Given this list of marker genes ADCYAP1, MAPK3, CAP1, CALCA, CAP2, MAPK8, ADORA3, CACNA1C, GIPR (NCBI Gene Id 2696), GNAS, CACNA1D, TMIGD3, AVPR2, GLP1R, CRHR1, MAPK14, P2RY11, ADORA2B, EDNRA, GUCA1A, STIM1, GUCA1ANB-GUCA1A, ACR, DRD5, ORAI1 (ORAI calcium release-activated calcium modulator 1), here is a description of the gene set: Human Gene Set: GOBP_POSITIVE_REGULATION_OF_CYCLASE_ACTIVITY Any process that activates or increases the activity of a cyclase. studied in species Homo sapiens